The following is a description of a gene set: studied in species Homo sapiens Human Gene Set: HP_THORACOLUMBAR_SCOLIOSIS Thoracolumbar scoliosis, and this is the list of marker genes: NIN, COL1A2, MYO18B, TBC1D24, GNPTAB, RSPRY1, AP1G1, PLK4, PAPSS2, MGAT2, MAPK8IP3, IL6ST, GLIS3, CHRNG, ROBO3, HNRNPK, COL2A1, SLC26A2, LONP1, IGBP1, PDGFRB, ASH1L, LHX3 (LIM homeobox 3), COL6A2, LBR, GNB2, CDH11, CLCF1, POP1, ROR2, HYAL1, ATG7 (NCBI Gene Id 105376952), IDH1, ALMS1, RPL10, TAF4, NEPRO, SLC35B2, ATP6V1B2, USP9X, CCN6, PIEZO2, MED12